The following is a description of a gene set: studied in species Homo sapiens Meconium stained amniotic fluid Human Gene Set: HP_MECONIUM_STAINED_AMNIOTIC_FLUID Amniotic fluid containing the earliest stools of a mammalian infant., and this is the list of marker genes: ALDH7A1, ATP8B1, NR1H4, ABCB4, SLC6A5, ABCB11, PHIP, ADNP, PLPBP